The following is a description of a gene set: Mouse Gene Set: GOBP_EAR_MORPHOGENESIS species: Mus musculus The process in which the anatomical structures of the ear are generated and organized. The ear is the sense organ in vertebrates that is specialized for the detection of sound, and the maintenance of balance. Includes the outer ear and middle ear, which collect and transmit sound waves; and the inner ear, which contains the organs of balance and (except in fish) hearing. Also includes the pinna, the visible part of the outer ear, present in some mammals., and this is the list of marker genes: Mapk1, Grxcr1, Grhl3, Ephb2, Tfap2a, Col2a1, Dvl3, Zeb1, Chrna9, Fgf10, Ripor2, Ptk7, Fgf8, Tprn, Clrn1, Osr2, Clic5 (chloride intracellular channel 5), Tecta, Fzd3, Myo3a, Slitrk6, Fzd6, Nipbl, Prrx2, Mapk3, Dvl2 (NCBI Gene Id 13543), Gsc (goosecoid homeobox), Nectin1 (nectin cell adhesion molecule 1), Myo15a, Enpp1, Gjb6, Tshz1 (teashirt zinc finger family member 1), Hoxa1, Frzb, Kcnq4, Fgf3, Sox2, Triobp, Zic3, Nectin3, Nr4a3, Pcdh15, Six4, Rest, Wnt3a, Ankrd24 (NCBI Gene Id 79265), Nherf1, Mafb, Mir96, Col11a1 (collagen, type XI, alpha 1), Cthrc1, Sparc, Sod1, Lrig1, Ntn1, Bloc1s5, Atp2b2 (NCBI Gene Id 22426), Ptprq, Fgf9, Eya1, Cdh23, Neurog1, Fgfr1, Ednra, Otx2, Sobp, Eya4, Dvl1 (dishevelled segment polarity protein 1), Spry2 (NCBI Gene Id 24064), Aldh1a3, Tcap, Dll1, Myc, Atp6v1b1, Celsr1, Gata3 (NCBI Gene Id 14462), Dlx5, Insig1, Myo7a (NCBI Gene Id 17921), Pou3f4, Lhfpl5, Tbx1, Whrn, Kcnq1, Gfi1, Grxcr2, Slc44a4, Otop1, Ush1c, Hpn, Chd7, Wnt5a, Tbx18, Sox9, Rac1, Nkx3-2, Prkra, Myo3b, Atp8a2, Pls1 (NCBI Gene Id 235532), Vangl2, Nog, Wdr19, Myo6, Ush1g, Gli2, Tmie (NCBI Gene Id 338530), Fzd2, Lrig3, Ttc39c, Wnt1, Pou4f3, Rpl38, Naglu, Fgfr2, Foxi1, Hmx3, Six2, Sec24b, Tbx3, Prrx1, Bcr, Strc, Chrna10, Cep290 (centrosomal protein 290), Gata2, Itga8, Otx1, Tifab, Pax8 (paired box 8), Foxg1, Ror2, Hmx2, Hoxa2, Edn1, Clrn2, Atoh1, Wdpcp, Msx1, Pdzd7, Dlx6, Tbx2, Insig2, Tshr, Gas1, Scrib, Hesx1, Zic1, Osr1 (NCBI Gene Id 23967), Abr, Stox1, Gbx2, Six1, Pax2